The following is a description of a gene set: species: Homo sapiens Human Gene Set: HP_ABNORMAL_CIRCULATING_METHIONINE_CONCENTRATION Any deviation from the normal concentration of methionine in the blood circulation. Abnormal circulating methionine concentration, and this is the list of marker genes: MMADHC, SKIC3, AHCY, SLC25A13, MAT1A, CBS, FAH, TFAM, MTR, MTRR, MTHFR, ADK, PRDX1, ABCD4, LMBRD1, GNMT, MMACHC